Given this list of marker genes PSMB6, TASP1, GGT6, PSMB7, GGTLC1, GGT7, PSMB9, GGT3P (gamma-glutamyltransferase 3 pseudogene), GGT1, GGTLC3, ASRGL1, PRSS50, PSMB8, PSMB11, PSMB5, BACE1 (NCBI Gene Id 23621), PSMB10, GGT5, GGTLC2, GGT2P, here is a description of the gene set: Human Gene Set: GOMF_THREONINE_TYPE_PEPTIDASE_ACTIVITY studied in species Homo sapiens Catalysis of the hydrolysis of peptide bonds in a polypeptide chain by a mechanism in which the hydroxyl group of a threonine residue at the active center acts as a nucleophile.